The following is a description of a gene set: studied in species Homo sapiens from publication Kaji T, Ishige A, Hikida M, Taka J, Hijikata A, Kubo M, Nagashima T, Takahashi Y, Kurosaki T, Okada M, Ohara O, Rajewsky K, Takemori T (PMID 23027924) Bcl6 germline deletion causes a prominent inflammatory disease, owing to over-expression of Th2 cytokines, and affects the properties of B cells prior to immunization. Therefore we established the B cell-specific Bcl6 deletion mice and analyze the gene expression of naive B cells under physiological conditions. Human Gene Set: GSE28737_FOLLICULAR_VS_MARGINAL_ZONE_BCELL_BCL6_HET_DN Genes down-regulated in heterozygous knockout of BCL6: follicular versus marginal zone source., and this is the list of marker genes: STAT5A, SPON1, KDR, FNBP1L, DGKH, VWC2L, ASIC5, IKBKE, CISH, ANKRD33, TAP1, TSPOAP1, GATAD2A, DAO, TXN (NCBI Gene Id 7295), ANGPTL4, BEND3, OLFM1, IL18BP, ELFN1, HPF1, UBA7, ATF5, CDKN2B (cyclin dependent kinase inhibitor 2B), SNRNP48, RECK, RHOD, DAXX, CDH22, SAMHD1, CEBPB, GBP6, PCGF5, BCAR1, TXNDC17, ABCB9, GPR84, ENPP1 (NCBI Gene Id 5167), MPZL2, GUCD1 (guanylyl cyclase domain containing 1), TUSC2, PDIA2, VPS37B, INSM2, TLCD1, MGAM, MFSD2A, SHISA2, PDCD1LG2, AARD, DUSP28, KLF1, PXDC1, ORAI1, RILPL2, PSMA7, SRSF1, SRPX2, DTX3L, HS3ST3B1, SLC28A2, P2RY13, ELOVL4, STRIP2, SMPDL3B, RD3, CD69, PMVK, XBP1, BNC2, COX17, CH25H, ART5, MCAM, PSMA5, EFNA2, SNAP23, N4BP1, DOCK6, LSAMP, DDX50, KCTD3, PPP1R15B, PLK2, F7, TSPAN15, NEUROD1, PPP1R12C, ANKIB1, GFI1, KRT23, VPS54, C11orf24, GJB2, CAMKK1, RARS1, POMT2, STK35, CMTR1, UBD, SPATA2, IFITM5, PRKAR1A, PLAC9, TMEM30A-DT, SUV39H2, C3orf52, MCF2L, SEPTIN2, CCND2, QKI, SOCS2, OAS1, SLC49A4, PHLDB1, MRPS2, PPP1R14C, KCMF1, ST7, BARHL1, KRT76, RAP2B, PNO1, RAP1B, MRPL21, GNB4, TUBB2B, MSN, CLEC5A, INSM1, BAG2, FCGR3A, EVPL, IL2RA, EID2, PML, RASGRP1, PRPF6, FPR1, NDRG1, RMDN3 (regulator of microtubule dynamics 3), TFEC, DLX2 (NCBI Gene Id 1746), OAS2, ARAP3, FER, IRF7, FAM221B, ZBTB32, NRP2, RASSF6, SLFN12L, CEMIP2, RASL11A, GRIN2C, ACTN1, UTP6, NUPR1, UBE2L6, PLA2G2F, HERC6, SEBOX, TXNL1, KCP, SLC1A7, MMEL1, MSTO1, NUP153, RSAD2 (radical S-adenosyl methionine domain containing 2), ST6GALNAC5, PSMA4, TUBA1A, LY6G6D, NKX2-4, MED12L, TOX4, SLC16A10, GOLPH3, RAB20, FHDC1, AFG2B, PLXNA1, SERPINE2, TREM1, MAPK13, SLC22A15, HBG2, AOPEP, GK, IRF1, MXD1, GADD45A, MFHAS1, LMNB1, AARS1, CALHM6, BATF2, PPP2R2C, SPO11, LMOD2